The following is a description of a gene set: Mouse Gene Set: GOMF_FIBRINOGEN_BINDING studied in species Mus musculus Binding to fibrinogen, a highly soluble hexameric glycoprotein complex that is found in blood plasma and is converted to fibrin by thrombin in the coagulation cascade., and this is the list of marker genes: Fbln1, Cdh5, Mfap2, Thbs1, Itgb3, Itga2b